The following is a description of a gene set: species: Mus musculus The directed movement of amino acids containing sulfur (cystine, methionine and their derivatives) into, out of or within a cell, or between cells, by means of some agent such as a transporter or pore. Mouse Gene Set: GOBP_SULFUR_AMINO_ACID_TRANSPORT, and this is the list of marker genes: Slc1a2, Slc3a1, Slc1a1, Slc7a13, Slc43a2, Ctns, Slc7a5, Slc7a11, Slc7a9, Mfsd12 (major facilitator superfamily domain containing 12), Slc1a4, Nfe2l1, Slc3a2